The following is a description of a gene set: Human Gene Set: HE_LIM_SUN_FETAL_LUNG_C1_MUC5AC_POS_ASCL1_POS_PROGENITOR_CELL MUC5AC+ ASCL1+ progenitor studied in species Homo sapiens from publication He P, Lim K, Sun D, Pett JP, Jeng Q, Polanski K, Dong Z, Bolt L, Richardson L, Mamanova L, Dabrowska M, Wilbrey-Clark A, Madissoon E, Tuong ZK, Dann E, Suo C, Goh I, Yoshida M, Nikolić MZ, Janes SM, He X, Barker RA, Teichmann SA, Marioni JC, Meyer KB, Rawlins EL (PMID 36493756), and this is the list of marker genes: FSTL5, ASCL1, RNF186, ACTL10, CACNA2D1 (calcium voltage-gated channel auxiliary subunit alpha2delta 1), NLGN1, CLDN10, TOX3, SULT2B1, PIGW, OXTR, SARDH, CPXM2, MAB21L4, DLL1, CRACDL, CDC25B, PLLP, FAM13C, CDH2, DLL3, RASD1, ESPN, PCP4, MFNG, RPRM, CALML3, MYCL, CHST9, CAMK1D, IGFALS, SAXO5, PHACTR3, LFNG, CEACAM6, IGSF1, DRAIC, SPX, LNX1, MUC5AC, RASAL1, SMOC2, CRISPLD2, HES6, SCNN1A, ACKR3, G0S2, SNCAIP, SRGAP1, KIF19, USHBP1, ABCG1, FMOD